Given this list of marker genes ACSL3, CPT1C, ACSL4, CPT2, ACSL1, CPT1A, CPT1B (carnitine palmitoyltransferase 1B), ACSL6, ACSL5, ACSBG2, ACSBG1, here is a description of the gene set: Pathway Definition from KEGG: Palmitate -- (ACSL,ACSBG) >> CPT1A/B/C >> CPT2 -> Palmitoyl-CoA studied in species Homo sapiens Human Gene Set: KEGG_MEDICUS_REFERENCE_BETA_OXIDATION_ACYL_COA_SYNTHESIS beta-Oxidation, acyl-CoA synthesis. Pathway ID: N00765. Pathway type: Reference. Pathway class: nt06020 beta-Oxidation in mitochondria.